Given this list of marker genes CSTA, RPTN, TGM1 (transglutaminase 1), HRNR, SPRR2F, CNFN, SPRR3, SCEL, EVPL, KLK7 (NCBI Gene Id 5650), KRT10, KAZN, KLK6, JUP, IVL, KRT77, KRT16, ANXA2, DSG3, FLG, SPRR2B, CAPN1, CASP14, NCL, KRT2, KRT1, PI3, PPL, SPRR1B, CST6, DSG4, TCHH, SERPINB5, CDSN, SPRR2G, SPRR2A, DSG2, SERPINB12, LORICRIN, SERPINB2, KRT75, LCE1D, DSG1, SPRR1A (NCBI Gene Id 6698), DSC3, SPRR2D, ANXA1, DSC2, SPRR2E, DSC1, HSPB1, PKP3, CYSRT1, PKP4, PKP2, PKP1, KRT14, FLG2, DSP, KRT17, here is a description of the gene set: Human Gene Set: GOCC_CORNIFIED_ENVELOPE species: Homo sapiens A type of plasma membrane that has been modified through addition of distinct intracellular and extracellular components, including ceramide, found in cornifying epithelial cells (corneocytes).